The following is a description of a gene set: Human Gene Set: TGAATGT_MIR181A_MIR181B_MIR181C_MIR181D species: Homo sapiens Genes having at least one occurence of the motif TGAATGT in their 3' untranslated region. The motif represents putative target (that is, seed match) of human mature miRNAs hsa-miR-181a, hsa-miR-181b, hsa-miR-181c and hsa-miR-181d (v7.1 miRBase)., and this is the list of marker genes: CPD, AFF4, CPEB4, EIF4A2, PAPOLG, EPB41L4B, ZNF615, INPP5A, KAT2B, ABI3BP, C2CD5, ZIC2, ZNF800 (zinc finger protein 800), GPBP1, OTUD4, RBBP7, PCDHA11, LRRN1, SOX6, C6orf62, BCLAF1, MYBPC1 (NCBI Gene Id 9116), PPP3R1 (protein phosphatase 3 regulatory subunit B, alpha), PURB, ADCY9, ABTB2, FMNL2, ETV6, CBLB, LBR, USP33 (NCBI Gene Id 23032), ATP2B1, RAB11FIP2, TCERG1, CNTN4, ZIC3, AKAP6, TGFBI, RALGAPB, PAK4, ATP2A2, SLC9A6, GRIK2, ST8SIA4, NFAT5, ZDHHC7, GABRA1, DOCK7, PTPN9, FOS, TMED5, RECK, GREM1, PCDHA4, BPTF, TAB3, TRAK2, BRWD1, B4GALT1, CHD7, PDGFRA, PAM, SCHIP1, TIMP3, LEMD3, EN2, ESR1, MBOAT2, GSE1, HOXC8, OSBPL3, ZNF664, DERL1 (derlin 1), NSMAF, FNDC3B, MAP3K3, CLIP1, PSAP, PAWR, MTMR9, GPD1L, ARHGEF7, SEC24C, SIX2, MAMDC2, CREBRF, PLEKHA3, SYNPR, SFR1, PIAS3 (protein inhibitor of activated STAT 3), SLITRK1, PCDHA5, IL1A, TRIM2, PKNOX2, NR6A1, ETF1, NKAIN2, ENAH, ADAMTS6, MSI1, TMEM94, DOCK10, TOGARAM1, EED, SIRT1, NIPBL, PRKCE, UNC5A, PHOX2B, PAK5, ADAMTS1 (NCBI Gene Id 9510), HSP90B1, UBE2B, CSNK1G1, SYPL2, FBXO11, ANO1, CCSER2, MECP2, SPECC1L, CACNB2, RGMA, TRIM13, GRK2, BAZ2B, AP1G1, ATP11C, PCDHA3, IPO5, BAIAP2 (BAR/IMD domain containing adaptor protein 2), GAPVD1, E2F7, FAM13B, EPHA4, ZNF468, MAP2K1, CLUH, PDK4, CBX4, INPP5E, EGR3, HCN2, PPP1R12B (NCBI Gene Id 4660), KANK1, LIN28B, MMP14, ROBO2, RPS6KB1, PTBP3, BTBD3, IRF2BPL, PCDHA12, PLCL2, SEL1L, BAZ2A (NCBI Gene Id 23525), PRTG (NCBI Gene Id 650816), HOXA11, RAN, ANKRD13C, ZBTB41, RABGEF1, LMBRD2, PCDHA1, ZC3H11A, CNTNAP3, PCDHA7, AGPAT1, PER2, TULP4, RNF6, ARL5A, ZNF655, KPNB1, LRP12, CARM1, HECA, SLC25A3, SRPK2, KLF6 (KLF transcription factor 6), RBM47, ACAP2, RLF, WSB1, LONRF1, MAT2A, RBM26, HLF, RPS6KA3, TBC1D4, ZNF280D, SEMA4G, GOLGA8EP (NCBI Gene Id 653749), HYOU1, MAP1A, MTCL1, CD4, ZNF207, IGSF9B, ARRDC3, CDYL, ESM1, NPEPPS, LRBA, UBE3C, CBX7, TNFRSF11B, RNF182, PCDHAC2, DNAJC13, IRS2, SNN, G3BP2, DIP2B, CACNA2D2, ZFP36L1, NAA20, SENP2, CUL3, PIK3R3, EYA3, CDH13, BRD1, PHLDA1, GRB10, CDC42BPA, NOVA1, GOLGA8B, CARF, SYT3, PRKCD, BMPR2, SEPTIN3, RTF1 (RTF1 homolog, Paf1/RNA polymerase II complex component), LIF, MEX3C, LIN7C, FNDC3A, CAMK2G, EPS15, SPIRE1, FHIP1B, RNF145, CNR1, MAPT, ILF3, LCLAT1, RNF34, RBM22 (RNA binding motif protein 22), RAB11A, IGF2BP2, JADE2, IGSF11, YWHAG, CREB1, DOP1A, PBX3, LARP4, TOX, CCN1, DDX3X, ARFGEF2, SRSF7, ATP1B1, DAZAP2, NMT2, FOXP1, SLC38A2, ADCY1, KLHL5, MIGA2, PLAG1, CGGBP1, SLC25A25, NR3C1, NCOA2, MIP, ATG5, BACH2, WSCD2, TMCC1, GRIA2, S100PBP, CDON, FAM3C, BHLHE40, DNAJC21, ADM, SLF2, COL16A1 (NCBI Gene Id 1307), ZFAND6, BIRC6, RNMT (NCBI Gene Id 8731), BCL2L11, NPTXR, ADAMTS18 (NCBI Gene Id 170692), YTHDF3, PALS1, JAZF1, MBNL2, RUNX1, GLS (glutaminase), LIN28A, AFF1, PI4K2A, YTHDF2, SOWAHA (sosondowah ankyrin repeat domain family member A), MINK1, CD163, STAG1, CTTNBP2NL, HIC2, HMGB2, PDIA6, MFSD6, C2orf69, OGT, SCOC, CHD9, CCNJ, FKBP1A, PHF20L1, PDLIM5, NAA50, ANKRD50, SOX5, RSPO2, PPIP5K2, LPP, MTPN, PLPPR4, KPNA1, PI4K2B, AKT3, PICALM, CAMSAP1, PCDHA6, LMO1, ATXN1, SS18L1, GOLGA1, DPP10, CARD11, FOXK1, IMPG1, GGT7, UBP1 (NCBI Gene Id 7342), ETS1, CREBZF, TBL1XR1, CTDSPL, ADGRB3, DHX57, MAPK1, AGFG1, MYH10 (NCBI Gene Id 4628), LPCAT1 (NCBI Gene Id 79888), LRRC32, PCDHA2, QKI, OSBPL8, PUM1, WDR20, ATP2B2, KCNMA1, SLC2A3, DUSP5 (dual specificity phosphatase 5), TRIM9, ARNT2 (NCBI Gene Id 9915), TOM1L1, GOLGA8A, PCDHA8, PALLD, TRIM71, CCAR1, PCNP, CPNE2, NPTN, THRB, GATA6, PABIR2, HOXB5, PHAF1, TSC22D2, CCNK, PPP1CB, SSX2IP, TBL1X, CLASP1, MAP3K10, FBXO33, PHF3, TBPL1, EN1, MED8, CBFA2T2, ACSL1, NAA15, KLF15, STC1, C16orf87, CUL5, GHITM, NCALD, ZC3H6, PNRC2, TARDBP, CRIM1, RSBN1, TNFSF11, CAPRIN1, ZBTB4, MIDEAS, NR4A3 (NCBI Gene Id 8013), CSNK1G3, IVNS1ABP, ITGB8, CNTNAP2, DDX3Y, DPYSL2, GALNT16 (NCBI Gene Id 57452), GOLGA8F, CBFA2T3, ADARB1, PCDHA13, TMEM196, ITGA3, SLITRK2, METAP1, LMO3, CDC73, MEAF6, INO80, MTURN, MED26, NLK, GSKIP, TNRC6B, E2F5, KCNK10, SENP1, MKNK2, SLC25A37, RAD21, PCGF2, PCDHA9, HYCC2, MB21D2, PCDHAC1, SYNE1, PLS1, BCL11A, WDR37, MTMR12, SEMA4C, MEX3B, NEGR1, GOLGA8G, DCUN1D1, MAP1B, USP42, TM9SF3, FIGN, TBC1D1, ARSJ (arylsulfatase family member J), POM121, PCDHA10, ATP8B5P, NR2C2, CAMTA2, GOLGA6L9, NRXN1, SPRY4, ADO, RAP1B, KLHL2, ACVR2A, TRIM3, GID4, SMAD7, DYNC1LI2, RSRP1, GRM5, BAAT, EPC2, NEXMIF, ADAM11, PLEKHJ1